The following is a description of a gene set: studied in species Mus musculus The portion of the plasma membrane surrounding a filopodium. Mouse Gene Set: GOCC_FILOPODIUM_MEMBRANE, and this is the list of marker genes: Gap43, Arf6, Ttyh1, Antxr1, Palm, Syne2, Itga3, Vasp, Utrn, Itgb3, Ninj1, Akap5, Dmd, Fzd9, Itgav, Myo10, Pdpn, Msn (moesin), Tbc1d10c